The following is a description of a gene set: species: Homo sapiens Human Gene Set: GOBP_PLATELET_ACTIVATING_FACTOR_METABOLIC_PROCESS The chemical reactions and pathways involving platelet activating factor, 1-O-alkyl-2-acetyl-sn-glycerol 3-phosphocholine, where alkyl = hexadecyl or octadecyl. Platelet activating factor is an inflammatory mediator released from a variety of cells in response to various stimuli., and this is the list of marker genes: PAFAH1B1, CHPT1 (NCBI Gene Id 56994), PLA2G7, PLA2G4C, PLA2G6 (phospholipase A2 group VI), PLA2G10, LPCAT2, PLA2G4A